The following is a description of a gene set: Transcriptional activation of mitochondrial biogenesis species: Homo sapiens Human Gene Set: REACTOME_TRANSCRIPTIONAL_ACTIVATION_OF_MITOCHONDRIAL_BIOGENESIS, and this is the list of marker genes: CAMK4, CARM1, SMARCD3, RXRA, TFB1M, NCOA2, TWNK, GABPA, SIRT3, TFAM, HCFC1, TBL1XR1, SIRT5, CYCS, GABPB1, ALAS1, PPARGC1B, NCOA6, TBL1X, TGS1, NCOA1, IDH2, POLG2, PERM1, PPRC1 (NCBI Gene Id 23082), SSBP1, MTERF1, TFB2M, MEF2D, ACSS2, GLUD1, HELZ2, NRF1, MED1, CALM1, HDAC3, PPARGC1A, MEF2C, NR1D1 (NCBI Gene Id 9572), CRTC1, SOD2, ATP5F1B, CRTC2, SIRT4, USP46, CREBBP, CHD9, GLUD2, ESRRA, CRTC3, POLRMT, CREB1 (NCBI Gene Id 1385), PPARA, ATF2, NCOR1